Given this list of marker genes PTPN18, IL18BP, IL37, PTPN5, STAT3, PTPN7, CASP1 (NCBI Gene Id 834), PTPN14, SIGIRR, TBK1, PTPN6, PTPN13, SMAD3, PTPN11, PTPN4, IL18R1, PTPN2, PTPN20, PTPN12, PTPN9, PTPN23, here is a description of the gene set: Reactome Pathway: Interleukin-37 signaling species: Homo sapiens part of: Interleukin-1 family signaling Interleukins (IL) are immunomodulatory proteins that elicit a wide array of responses in cells and tissues. Interleukin 37 (IL37), also known as IL 1F7, is a member of the IL 1 family. Isoform b of IL37 (referred just as IL37) is synthesized as a precursor that requires processing (primarily by caspase 1) to attain full receptor agonist or antagonist function. Both full length and processed IL37 can bind to the IL 18 binding protein (IL 18BP) and the Interleukin 18 receptor 1 (IL 18R1). Upon binding to the IL18R1, IL37 recruits Single Ig IL 1 related receptor (SIGIRR). The IL37:IL18R1 complex can activate phosphorylation of Signal transducer and activator of transcription 3 (STAT3), Tyrosine protein kinase Mer and Phosphatidylinositol 3,4,5 trisphosphate 3 phosphatase and dual specificity protein phosphatase PTEN and can also inhibit Nuclear factor NF kappa B p105 subunit (NFKB). Processed IL37 can be secreted from the cytosol to the extracellular space or translocated into the nucleus. Full length IL37 can also be secreted from the cytosol to the extracellular space. Processed IL37 can bind with Mothers against decapentaplegic homolog 3 (SMAD3) in the cytosol and then translocate to the nucleus, where it facilitates transcription of Tyrosine protein phosphatase non receptors (PTPNs). These events ultimately lead to suppression of cytokine production in several types of immune cells resulting in reduced inflammation.